Given this list of marker genes Npnt, Ppargc1b, Gpld1, Hpn, Mef2c, Tnf, here is a description of the gene set: Any process that modulates the frequency, rate or extent of alkaline phosphatase activity, the catalysis of the reaction: an orthophosphoric monoester + H2O = an alcohol + phosphate, with an alkaline pH optimum. Mouse Gene Set: GOBP_REGULATION_OF_ALKALINE_PHOSPHATASE_ACTIVITY studied in species Mus musculus